The following is a description of a gene set: from publication Soucek L, Lawlor ER, Soto D, Shchors K, Swigart LB, Evan GI (PMID 17906636) Human Gene Set: SOUCEK_MYC_TARGETS Chemokine genes up-regulated within 2 hr of c-Myc activation in a mouse model of Myc-induced pancreatic beta-cell tumorigenesis. species: Mus musculus An association between inflammation and cancer has long been recognized, but the cause and effect relationship linking the two remains unclear. Myc is a pleiotropic transcription factor that is overexpressed in many human cancers and instructs many extracellular aspects of the tumor tissue phenotype, including remodeling of tumor stroma and angiogenesis. Here we show in a beta-cell tumor model that activation of Myc in vivo triggers rapid recruitment of mast cells to the tumor site-a recruitment that is absolutely required for macroscopic tumor expansion. In addition, treatment of established beta-cell tumors with a mast cell inhibitor rapidly triggers hypoxia and cell death of tumor and endothelial cells. Inhibitors of mast cell function may therefore prove therapeutically useful in restraining expansion and survival of pancreatic and other cancers., and this is the list of marker genes: CCL2, CCL7, LILRB1, CXCL6, CXCL2, CCL15, CSF2RB, CCL21, KLF6 (NCBI Gene Id 8025), CXCL13, CCL5